Given this list of marker genes RAB33A, IGF1R, ZKSCAN2, CHIC1, LDB2, PRDM16, STX1B (syntaxin 1B), KNDC1, CYP2J2, SRGAP3, MBOAT2, EPB41L2, TRAF1, PRR16, ZNF467, VDR, BICC1, CBX7, TIE1, SCARF1, LGI3, ADAM22, CNTN1, SLC6A15, ZNF484, ANKZF1, GAA, SCAPER, TMEM144, RRAS, CBX6, GARIN5A, DOCK9, PLSCR4, LPP, ZKSCAN1, MAP7, JAM3, JAG2, OCLN (NCBI Gene Id 4950), RORA, NFE2L3, SPRR1A, HP1BP3, NAA30, CCDC71, KRT27, DCAF6, PRDM1, MARCHF10, ATXN1, ARHGEF10, ZRANB1, AK1, CHST2, ABLIM1, SLTM, CCDC112, DNM1, CCSER1 (coiled-coil serine rich protein 1), ANKS1B, LIX1L, SMIM17, GPRC5B, VNN1, NMT1, RCC2, UFSP2, FMN2, PADI6, NBEA, P2RX4, RORC, FKBP7, LHX9, LACTB, SLC12A2, PIERCE1, LAMB2, PROCR, CCM2L, PHLPP1, CILK1, RBP1, ANGPT1, PLXDC2, RASAL2, KAZALD1, DYRK4, TTLL7, LENG8, LARGE1, PLN, PCLO, CCL27, MAST2, FAM168A, MYOM1, CEACAM21, EXT2, HES1, UTRN, PTPRZ1, CEACAM4, PRRX1, FSTL1, TNS1, ZAN, EGR3, ZFP92, EPHA5, CLIP4, CLDN3, DUSP15, BMP8A, PRRT3, FUT10, FOXN3, IL4, TUBA3D, HLF, HOXA5, CRIM1, TCF7L1, ZBTB39, CASTOR2, AQP4, CEROX1, C11orf54, NT5DC3, TINF2, KDF1, RNF151, MGA, FGF19, AKAP9, SLC9B2, PCDH9, LCA5, MYO5C, ADGRL1, CLEC2L, SETBP1, TNFRSF8, ARFRP1, ST8SIA4, COL18A1, GBP6, SHROOM3, FILIP1, STARD6, SRGAP1, CSAD, SMYD3, ZNF354A, TSBP1, MET, DSG2, ADGRD1 (NCBI Gene Id 283383), ELAVL4, PCDH1, NPY1R, FLRT3, PTPN21, EFNB2, GDAP1, LCE1B (NCBI Gene Id 353132), SIX5, HOXA3, SCP2D1, TWIST2 (NCBI Gene Id 117581), PROX1, IFT43, ADARB1, EYA2 (EYA transcriptional coactivator and phosphatase 2), HM13, GNAS, SLC16A9, PCGF2, ZNF260, LRCH4, EFNA4, C9orf152, PEBP1, NSRP1, HSD3B2, FAAH, SPATA7, SYNPO, MECOM, ZNF784 (NCBI Gene Id 147808), HAVCR1, GJD2, GM2A, RHOQ, ZMYND11, DOCK8, LDHAL6B, ZBTB20, KRT7, CGNL1, GLA, ZMYM6, SKI, KIF6, ZDHHC17, ZFP1, BEND5, CAVIN3, CACNA1C, IFT122, ELAPOR1, BACE2, HOXA10 (NCBI Gene Id 3206), IGHE, JAM2, BCL9L, HBEGF, SYN2, here is a description of the gene set: Genes in the expression cluster 'LT-HSC Shared': up-regulated in long term hematopoietic stem cells (LT-HSC) from adult bone marrow and fetal liver. Mechanisms regulating self-renewal and cell fate decisions in mammalian stem cells are poorly understood. We determined global gene expression profiles for mouse and human hematopoietic stem cells and other stages of the hematopoietic hierarchy. Murine and human hematopoietic stem cells share a number of expressed gene products, which define key conserved regulatory pathways in this developmental system. Moreover, in the mouse, a portion of the genetic program of hematopoietic stem cells is shared with embryonic and neural stem cells. This overlapping set of gene products represents a molecular signature of stem cells. from publication Ivanova NB, Dimos JT, Schaniel C, Hackney JA, Moore KA, Lemischka IR (PMID 12228721) studied in species Mus musculus Human Gene Set: IVANOVA_HEMATOPOIESIS_STEM_CELL_LONG_TERM